Given this list of marker genes Hsd3b9, Sec14l2, Fdxr, Mbtps2, Lipa, Prkg1, Hsd3b6, Akr1c14, Gpr146, G6pdx (NCBI Gene Id 14381), Hsd3b7, Ddx20, Ces1f, Cyp51, Tspo, Egr1, Ces1h, Cyp7a1, Star, Igf1r, Acbd3 (acyl-Coenzyme A binding domain containing 3), Prox1, Cyp27a1, Cmtm2a, Mvk, Cyp17a1, Lhcgr, Tm7sf2, Lep, Sf1, Ch25h, Nr5a2, Msmo1, Nr0b1, Hsd3b1, Mapk1, Dkkl1, Hsd3b2, Gprc6a, Insig2, Srd5a2 (NCBI Gene Id 94224), Il1a, Apob, Apoa1, Ces1c, Scap, Akr1c18, Scarb1, Pbx1, Cyp11a1, Cacna1h, Igf2, Gm2044, Med1, Hrh1, Sod1, Wnt4, G6pd2, Cftr (cystic fibrosis transmembrane conductance regulator), Nr1d1, Bmp2 (bone morphogenetic protein 2), Srebf1, Stard4, Cyb5r1, Cyp11b1, Armc5 (armadillo repeat containing 5), Rest, Ces1e, Adora2b, Lpcat3, Hsd3b4, Mvd, Ces1b, Aqp8, Hsd17b7, Hmgcs2 (3-hydroxy-3-methylglutaryl-Coenzyme A synthase 2), Cyp21a1, Hsd17b3, Npy1r, Fgf1, Akr1c6, Prkaca, Cyp8b1, Abcg4, Fdx1, Abcg1, Malrd1, Ifng, Bglap, Dhcr7, 3110082I17Rik, Cyp7b1, Pde8b, Bmp5, Ppargc1a, Igf1, Erlin1 (NCBI Gene Id 98152), Fgfr4 (NCBI Gene Id 212063), Hsd17b2, Hsd3b5, Hsd17b8, Ggcx, Dkk3, Hsd11b1, Tecr, Cyb5r2, Dhcr24, Bmp6, Akr1c20, Atp1a1, Bglap2, Dhrs11, Igfbp7, Sc5d, Pmvk, Cyp24a1, Cyp27b1, Pex2, Hsd17b1, Dab2, Sdr42e1, Hsd17b11, Snai2, Crh, Paqr3, Asah1, Ces1a, Erlin2, Insig1, Faxdc2, Gnai1, Inhba, Fdps, H6pd, Cga, Fgf15, Npc1l1, Prkaa2, Cyb5r3, Hsd3b8 (hydroxy-delta-5-steroid dehydrogenase, 3 beta- and steroid delta-isomerase 8), Dgkq (NCBI Gene Id 13141), Hsd17b12, Por, Cyp2r1, Fdft1 (farnesyl diphosphate farnesyl transferase 1), Bmpr1b, Prkaa1, Clcn2, Hsd3b3, Scp2 (NCBI Gene Id 99990), Akr1c21 (aldo-keto reductase family 1, member C21), Nfkb1, Cyp19a1, Ces1d, Hmgcs1, Creb1, Stard3, Nr3c1, Qki, Gfi1, Lss, Sirt1, Ces1g, Nsdhl, Hint2, Hmgcr, Dhh, Lbr, Cyp1a1, Tnf, Snai1, Cyp11b2, Srebf2, Fshb, Idi2, Cyp39a1, Ebp, Apoe, Sqle, Gh, Idi1, Erg28, Srd5a1, here is a description of the gene set: The chemical reactions and pathways resulting in the formation of steroids, compounds with a 1,2,cyclopentanoperhydrophenanthrene nucleus; includes de novo formation and steroid interconversion by modification. Mouse Gene Set: GOBP_STEROID_BIOSYNTHETIC_PROCESS studied in species Mus musculus